The following is a description of a gene set: An supramolecular fiber that consists of an insoluble core of polymerized tropoelastin monomers and a surrounding mantle of microfibrils. Elastic fibers provide elasticity and recoiling to tissues and organs, and maintain structural integrity against mechanical strain. Mouse Gene Set: GOCC_ELASTIC_FIBER species: Mus musculus, and this is the list of marker genes: Fbln1, Mfap4, Efemp2, Fbln5, Eln